The following is a description of a gene set: species: Homo sapiens Human Gene Set: MIR4297 from publication Chen Y, Wang X (PMID 31504780) Genes predicted to be targets of miRBase v22 microRNA hsa-miR-4297 in miRDB v6.0 with MirTarget v4 prediction scores > 80 (high confidence targets)., and this is the list of marker genes: TGFBR1, CASTOR3P, ATXN1L, ARHGEF39, APOBEC3A, SH3PXD2A, PHOSPHO1, ZIC3, ATP8A1, TNFRSF10B, PWWP3B, APOBEC3B, KCNRG, ANKRD1, PPARGC1B, SFT2D2, CHN2, SEMA5A, CUX2, TFDP1, PPP6R1, EFNB1, THSD7A, CCDC62, ADCY1, FBXL2, RORC, ZNF491, FAM83A, SHISA6, ELAPOR2, CARM1, ABL2, C14orf132, CES5A, SYTL4, MPDU1-AS1, NPNT, MSI2, DUSP22, CIBAR1, APOBEC3G, SLCO2A1, CSNK1D, BTG4, THUMPD1, TMTC1, POTEM, MARF1, CNTN5, CLMN, HERPUD1, GMEB1, CBX5, RIMKLA, FBXO32, PAFAH1B1, CPEB3, SMG7, DCLK2, PNKD, STX12, SMARCAD1, LSM11, IFFO2 (intermediate filament family orphan 2), ANO3 (anoctamin 3), LRRTM2 (leucine rich repeat transmembrane neuronal 2), KDM5B, BARHL2, SHC3, UBXN10, SHROOM4, GABBR1, PCGF5, ZNF608, SGPP2, CPEB2, GRAMD1B, UBAP2L, DESI1, RPL36A-HNRNPH2, ABHD13, GANC, HTR2A, TCF24, MMP14, TBC1D9, FGF1, BEST3, DOCK4, OSBPL8, PI4KB, ALKBH5, ULK2, PTPRE, ZNF609 (NCBI Gene Id 23060), NWD1, WDFY3, BCR, MORC4, MPP3, PAIP2, SUV39H2, ZNF629, MINAR1, NTN1, ACTC1, DLG2, LHX6, SYNPO2, FZD7, STAMBP, STS, POLR2G, SLC4A8, JMY, RCOR1, BACE2, ABCD3, CELF2, ABCC4, UBXN7, RBPJ, ZNF559-ZNF177, SARDH (NCBI Gene Id 8017), CADM1, FBLIM1, IL4R, LATS1, APOL6 (apolipoprotein L6), PPFIA1 (NCBI Gene Id 8500), MATCAP1, TSHR, SRGAP1 (SLIT-ROBO Rho GTPase activating protein 1), TCEAL7, IFT20, KANSL3, ZNF790, COX20 (NCBI Gene Id 116228), RASSF5, PEX19, CLK3, KCNN1, UBE2E3, VEZF1, CHST9, HUNK, PLA2G2F, FCGR2B, AQP4 (NCBI Gene Id 50660), RPP14, AFG2A, KIF1A, PDZRN3, MAPT, ENSG00000255537, STEAP2, POU2F2, ABRA, ZNF200, FOXN3, MXD4, LACC1, NOS1, MAPK10, ORMDL2, CAMK2G, POU3F2, PDX1, MAU2, UNC5D, NEDD4L, NCOA3, SNX30, GPX5, SEMA3D, SHOC2, SMIM10, SERPINA1, ATP6V1A, ZNF550, MID2, FYCO1